The following is a description of a gene set: from publication Darwiche N, Ryscavage A, Perez-Lorenzo R, Wright L, Bae DS, Hennings H, Yuspa SH, Glick AB (PMID 17525749) Genes up-regulated in squamous cell carcinoma (SCC) compared to normal skin. studied in species Mus musculus Chemical induction of squamous tumors in the mouse skin induces multiple benign papillomas: high-frequency terminally benign low-risk papillomas and low-frequency high-risk papillomas, the putative precursor lesions to squamous cell carcinoma (SCC). We have compared the gene expression profile of twenty different early low- and high-risk papillomas with normal skin and SCC. Unsupervised clustering of 514 differentially expressed genes (P<0.001) showed that 9/10 high-risk papillomas clustered with SCC, while 1/10 clustered with low-risk papillomas, and this correlated with keratin markers of tumor progression. Prediction analysis for microarrays (PAM) identified genes that distinguished the two papilloma classes, and a majority of these had a similar expression pattern in both high-risk papillomas and SCC. Additional classifier algorithms generated a gene list that correctly classified unknown benign tumors as low- or high-risk concordant with promotion protocol and keratin profiling. Reduced expression of immune function genes characterized the high-risk papillomas and SCC. Immunohistochemistry confirmed reduced T-cell number in high-risk papillomas, suggesting that reduced adaptive immunity defines papillomas that progress to SCC. These results demonstrate that murine premalignant lesions can be segregated into subgroups by gene expression patterns that correlate with risk for malignant conversion, and suggest a paradigm for generating diagnostic biomarkers for human premalignant lesions with unknown individual risk for malignant conversion. Mouse Gene Set: DARWICHE_SQUAMOUS_CELL_CARCINOMA_UP, and this is the list of marker genes: Pdcd5, Mt1, Ttll11, Man2a2, Rnf181, Pgam1, Eno1, Pds5b, Hbb-y, Sprr2k, Snhg3, Ppic, Arg1, Chka, Ftl2-ps, Tektip1, Gkn3, Icam1, Mrps18a, Eng, Tmem65, Spns3, Lyz2, Gpr15lg, Klf13 (NCBI Gene Id 80528), Hspd1, Cxcl16, Cacybp (calcyclin binding protein), Ext2, Ywhab, Sfpq, Il1b, Prg3, Rasip1, Rubcn, Dynll1, Psg23, Id1, Rhoh, Plac8, Nfe2l2, Cmpk2, Ccdc38, Cx3cl1, Gsk3b, Drd5 (dopamine receptor D5), Clvs1, Uck2 (uridine-cytidine kinase 2), Esd, Cited2, Dnajc1, Sprr2h, Fes, Spp1, Bmyc, Nek4, Trp73, Elavl1, Acot10 (NCBI Gene Id 64833), Tmem248, Chi3l1, H2az1, Jag1, Prss3b, Or8b12i, Ncl, Plekha4, Tcp1, Samhd1, Rnase2b, Pfkl, Stx16, Psg28, 4930547E14Rik, S100a11, Slpi, Rab2b, Ldha, Polr1has, Camk4, Ptprcap, 2610042L04Rik, Ube2c, Lce3b (NCBI Gene Id 66344), Tgfa, 4921517D16Rik, Klk9, Ltbp4, Rps6ka4, Cdc42ep2, Gdf5, 1110038B12Rik, Cct4, Capn2, Sod1, Sdr9c7, Galk1, Lypd2, Snhg9, Klk6, Nrsn1, Elapor1, Sun1, Ide, Sprr2b, Morn5, Ryr1, Chpt1, 2900064F13Rik, Ifitm3, Chp1, Acan, Lif, Best1, Saraf, Gsta1, Creld1, Arap1, Qdpr, Pgk1, Map2k5, Axl, Sprr2g, Cd248, Enah, Fabp4, Ftl1, Trmt1, Pmepa1, Rnf19a, Srm, Smim8, Sprr2f, 4930527J03Rik, Ugt2b37, Eef1d, Hrc, Cacna1e, Rpl39, 1700105P06Rik, H2-M9, Gclm, Bid, Rab5if, Eef1b2, Sod3, Ncan, Sprr2i, Rptn, Mcam, Suclg2, Baiap2, Srsf1, Plet1, Spic, Nhp2, Hbs1l, Ctsl, Stfa1, Arl2, Fam162a, Wfdc2, Hexa, Vhl, S100a8, Ly6e, Cox5b, S100a9, Txn1, Bzw1